Given this list of marker genes Fen1, Irf8, Rab2a (NCBI Gene Id 93773), E2f1, Klf1, Pias2, Nap1l2, Atf1, Tfdp1, Smarcb1, Tcf12, Id1, Gm4739 (NCBI Gene Id 15352), Sp3, Supt4a, Pla2g6, Nfix, Hmgn2, Zbtb17, Fosl2, Aurkb, Bmi1, Pbx2, Mbd4, Smad6, Srsf2, Cenpb, Foxh1, Cdkn2d, Rxra, Hmgb3, Pias3, Cux2, Ankrd49, Dhx9, Per3, Rab7, Zfp35, Hnrnpdl, Cenpa, Eif4a2, Exo1, Gata1, Polr2j, here is a description of the gene set: Aberrant expression of the human homeobox-containing proto-oncogene TLX1/HOX11 inhibits hematopoietic differentiation programs in a number of murine model systems. Here, we report the establishment of a murine erythroid progenitor cell line, iEBHX1S-4, developmentally arrested by regulatable TLX1 expression. Extinction of TLX1 expression released the iEBHX1S-4 differentiation block, allowing erythropoietin-dependent acquisition of erythroid markers and hemoglobin synthesis. Coordinated activation of erythroid transcriptional networks integrated by the acetyltransferase co-activator CREB-binding protein (CBP) was suggested by bioinformatic analysis of the upstream regulatory regions of several conditionally induced iEBHX1S-4 gene sets. In accord with this notion, CBP-associated acetylation of GATA-1, an essential regulator of erythroid differentiation, increased concomitantly with TLX1 downregulation. Coimmunoprecipitation experiments and glutathione-S-transferase pull-down assays revealed that TLX1 directly binds to CBP, and confocal laser microscopy demonstrated that the two proteins partially colocalize at intranuclear sites in iEBHX1S-4 cells. Notably, the distribution of CBP in conditionally blocked iEBHX1S-4 cells partially overlapped with chromatin marked by a repressive histone methylation pattern, and downregulation of TLX1 coincided with exit of CBP from these heterochromatic regions. Thus, we propose that TLX1-mediated differentiation arrest may be achieved in part through a mechanism that involves redirection of CBP and/or its sequestration in repressive chromatin domains. from publication Riz I, Akimov SS, Eaker SS, Baxter KK, Lee HJ, Mariño-Ramírez L, Landsman D, Hawley TS, Hawley RG (PMID 17213805) species: Mus musculus Mouse Gene Set: RIZ_ERYTHROID_DIFFERENTIATION_CCNE1 Selected gradually up-regulated genes whose expression profile follows that of CCNE1 in the TLX1 Tet On iEBHX15-4 cells (pro-erythroblasts).